Given this list of marker genes ZDHHC2, ZDHHC14, GOLGA7, ZDHHC18, ZDHHC20, ZDHHC12, ZDHHC8, ZDHHC19, ZDHHC21, ZDHHC15, ZDHHC7, CLIP3, ZDHHC9, ZDHHC3, ZDHHC11, here is a description of the gene set: Human Gene Set: GOBP_PEPTIDYL_L_CYSTEINE_S_PALMITOYLATION studied in species Homo sapiens The covalent attachment of a palmitoyl group to a sulfur (S) atom within a cysteine residue to form peptidyl-S-palmitoyl-L-cysteine.